The following is a description of a gene set: Human Gene Set: HP_SINGLE_FIBER_EMG_ABNORMALITY studied in species Homo sapiens Single fiber EMG abnormality Abnormality in single fiber EMG recording, a technique that allows identification of action potentials (APs) from individual muscle fibers., and this is the list of marker genes: COL13A1, SLC5A7, SLC25A1, ALG2, GFPT1, DPAGT1, GMPPB, ALG14